Given this list of marker genes TP53BP2, PPP1R13L, POU4F2, AKT3, PPP1R13B, TP73, TP53, PHF20, AKT2, TP63, AKT1, POU4F1, BANP, ZNF385A (NCBI Gene Id 25946), here is a description of the gene set: Regulation of TP53 Activity through Association with Co-factors studied in species Homo sapiens Human Gene Set: REACTOME_REGULATION_OF_TP53_ACTIVITY_THROUGH_ASSOCIATION_WITH_CO_FACTORS